Given this list of marker genes Slc25a13, Slc8a3, Slc25a14, Slco4a1, Slc10a1, Slc4a11, Slc39a6, Slc12a1 (NCBI Gene Id 99066), Slc6a2, Slc1a7, Slco5a1, Slc26a7, Slc35c1, Slc25a31 (NCBI Gene Id 73333), Slc9b2, Slc13a5, Slc25a24, Slc16a1, Slc5a10, Ank, Slc6a14, Slc10a7, Slc10a4, Slc18a1, Slc35e4, Slc28a1, Slc12a8, Slc35d3, Slc20a1, Slc20a2, Gm5134, Slc8a1, Slc8a2 (solute carrier family 8 (sodium/calcium exchanger), member 2), Slc22a29, Slc44a1, Slc1a2, Slc22a7, Slc6a8, Slc25a30, Letm1, Ghitm, Mfsd4b1 (NCBI Gene Id 215929), Slc25a3, Slc24a3, Slc25a19, Slc12a2 (NCBI Gene Id 20496), Slc9a6 (solute carrier family 9 (sodium/hydrogen exchanger), member 6), Slc4a5, Slc41a3, Slc6a4, Slc9a2, Slc6a3, Slc1a1, Slc18a3, Slc25a26, Slco6c1 (NCBI Gene Id 96889), Slc12a5, Slc35d2, Slc6a9, Slco1a1, Slc35e1, Slc17a1, Slc7a11, Slc5a1, Slc17a8, Slc34a2, Slc9b1, Slc10a2, Slc9a8, Slc16a2, Slc26a5, Slc9a3, Slc24a4, Slc35a1, Slc13a3, Slc6a13, Slc10a5, Slc8b1, Slc16a10, Slc10a4-ps, Slc24a5, Slc47a2, Slc7a13, Slc15a2, Slc45a3, Slc13a1, Slc36a4, Slc25a1, Slc35a3, Slc9a4, Clcn5, Slc37a2, Slco1b2, Slc41a1 (solute carrier family 41, member 1), Slc39a14, Slc18a2, Slc6a20b, Slc39a4, Slc10a3, Slc30a8, Slc23a2, Slc3a2, Slc46a3, Slc22a5, Slc25a4, Tmem165, Slc5a9, Slc2a8, Slc26a2, Mfsd2b, Slc47a1, Slc45a2 (NCBI Gene Id 22293), Slc24a2, Mfsd12, Slc16a7, Chp1, Slc25a5, Slc35a5, Slc4a7, Slco1a6, Cdh17, Slc16a12, Slc22a1, Slc16a11, Slc37a4, Clcn7, Slc23a1, Slc7a9, Slc29a1, Slc30a1, Slc13a2, Slc35e3, Slco1a8, Slc35a2, Slc16a4, Ucp2, Slc1a6, Slc16a14, Slc26a9, Slc22a6, Slc44a5, Slc6a20a, Xpr1, Slc5a8, Slc15a4, Slc35d1, Slco2b1, Slc5a12, Slc9a5, Slc7a6, Slco1a4, Slc24a1, Slc28a2b, Slc44a2, Slc17a7, Slc16a5, Slc19a1, Slc25a25, Slc26a11, Slc22a8, Slc4a9, Slc38a5, Slc22a3 (solute carrier family 22 (organic cation transporter), member 3), Slc26a3, Slc22a4, Slc38a3, Slc34a3, Slc25a21, Slc30a9, Slc30a10, Tmem241, Slc6a15, Slc44a4, Clcn3, Slc15a3, Slc25a11, Slc6a12, Ctns, Slc16a3, Slc25a16, Slc15a1, Slc39a8, Slc9a7, Slc2a13, Slco3a1, Slc17a4, Slc46a1, Slc17a9, Slc4a3, Slc2a4, Slc25a23 (solute carrier family 25 (mitochondrial carrier; phosphate carrier), member 23), Slc35c2, Slc28a3, Slc38a7, Slc34a1 (solute carrier family 34 (sodium phosphate), member 1), Slc6a5, Slc12a4, Slc37a1, Slc30a4, Slc35b3, Slco2a1, Slc6a17, Slco1a7, Slc45a1, Slc16a8, Slc5a2, Slc13a4, Slc12a6, Slc5a7, Slc11a1, Slc12a3 (NCBI Gene Id 20497), Slc9a9, Slc25a12, Slc9c1 (solute carrier family 9, subfamily C (Na+-transporting carboxylic acid decarboxylase), member 1), Slc30a5, Slc6a11, Slc7a5, Slc38a4, Slc9a1, Slc12a9, Slc26a6, Slc26a8, Slc32a1, Slc22a19, Slc6a19, Slc16a13, Slc17a2, Slc22a28, Slc39a10, Slc5a6, Slc30a2, Slc4a1, Slc5a5, Slc6a1 (solute carrier family 6 (neurotransmitter transporter, GABA), member 1), Slc35b1, Slc25a42, Slco6d1, Slco4c1, Slc4a8, Slc1a4, Slc4a2 (solute carrier family 4 (anion exchanger), member 2), Slc10a6, Slc17a6, Slco1a5, Slc25a15, Slc22a26, Slc25a10, Slc6a7, Slc4a10, Tmco3, Clcn6, Slc11a2, Slc35b2, Slc6a6, Slco1c1 (solute carrier organic anion transporter family, member 1c1), Slc28a2, Mfsd1, Slc12a7, Mcu, Mfsd2a, Slc39a12, Slc36a1, Slc17a5, Slc15a5, Slc26a10 (NCBI Gene Id 97639), Slc1a3, Slc1a5, Slc5a3, Slc38a1, Slc36a2, Clcn4, Slc26a4, Slc30a3, Slc38a2, Slc6a18, Slc5a11, Slc36a3, Slc26a1, Slc4a4, Slc39a5, Slc18b1, Slc5a4a, Slc25a22, Slc22a18, Slc35e2, Slc5a4b, Slc22a27, Slc22a30, Slc25a18, Slc45a4, Slc25a17, Slc7a8, here is a description of the gene set: Enables the transfer of a solute from one side of a membrane to the other, up its concentration gradient. The transporter binds the solute and undergoes a series of conformational changes. Transport works equally well in either direction and is driven by a chemiosmotic source of energy, not direct ATP coupling. Secondary active transporters include symporters and antiporters. Mouse Gene Set: GOMF_SECONDARY_ACTIVE_TRANSMEMBRANE_TRANSPORTER_ACTIVITY species: Mus musculus